The following is a description of a gene set: from publication Guo S, Copps KD, Dong X, Park S, Cheng Z, Pocai A, Rossetti L, Sajan M, Farese RV, White MF (PMID 19596788) We used a Cre-loxP approach to generate mice with varied expression of hepatic Irs1 and Irs2 to establish the contribution of each protein to hepatic nutrient homeostasis. While nutrient-sensitive transcripts were expressed nearly normally in liver lacking Irs2 (LKO2 mice), these transcripts were significantly dysregulated in liver lacking Irs1 (LKO1 mice) or Irs1 and Irs2 together (DKO mice). Similarly, a set of key gluconeogenic and lipogenic genes was regulated nearly normally by feeding in liver retaining a single Irs1 allele without Irs2 (DKO/1 mice) but was poorly regulated in liver retaining one Irs2 allele without Irs1 (DKO/2 mice). DKO/2 mice, but not DKO/1 mice, also showed impaired glucose tolerance and insulin sensitivity-though both Irs1 and Irs2 were required to suppress hepatic glucose production during hyperinsulinemic-euglycemic clamp. In contrast, either hepatic Irs1 or Irs2 mediated suppression of HGP by intracerebroventricular insulin infusion. After 12 weeks on a high-fat diet, postprandial tyrosine phosphorylation of Irs1 increased in livers of control and LKO2 mice, whereas tyrosine phosphorylation of Irs2 decreased in control and LKO1 mice. Moreover, LKO1 mice -- but not LKO2 mice -- that were fed a high-fat diet developed postprandial hyperglycemia. We conclude that Irs1 is the principal mediator of hepatic insulin action that maintains glucose homeostasis. Transcripts dependent upon IRS1 and IRS2 for normal expression in liver. species: Mus musculus Mouse Gene Set: GUO_TARGETS_OF_IRS1_AND_IRS2, and this is the list of marker genes: Aff4 (AF4/FMR2 family, member 4), Bysl, Fdps, Gemin2 (NCBI Gene Id 66603), Hmgcr, Nudt7, Cdip1, Gch1, Lbhd1, Tubb4b, Cebpb, Sqle, Pck1 (phosphoenolpyruvate carboxykinase 1, cytosolic), Gne, Taok3, Elk4, Nsdhl, Gck, Eci2, Slc7a2, Sc5d, Cyp51, Galnt2, Tat, Mogs, Ppargc1b, Pitpnc1, Rbms1, Tnfrsf1b, Pde7b, Hmga1, Ctps1, G6pc1, Abcg8, Grn, Dkc1, Acaca, Fus, Nipbl, Insr, Bcl3, Ppm1a, Sirt3, Pcsk9, Lss, Rbpms, Tubb5, Gk, Dnaja1, Lpp, Mvd, Tm4sf4, Syt1, Abcg5, Agtr1a, Dnajb2, Ctsl, Dhcr7, Prok1, Klf9, Gm16551, Mvk, Hsph1, Crybg1, Sgk2, Actb, Abcb4, Gns, Casp6, Rcan1, Ppp1r3b, Ppargc1a, Ppp3ca, Fdft1, Hsp90aa1, Rnd1, Pcbp4, Ccni, Cpt1a, Mxi1, Nudt4, Cdc34b, Il6ra (interleukin 6 receptor, alpha), Atxn2, Gfra1, Scarb1, Msmo1, Ifi35, Acat2, Dhcr24, Nfe2, Rbm39, Nr1i2, Arhgap5, Cacybp, Igfbp1, Rbl2